The following is a description of a gene set: from publication Luckey CJ, Bhattacharya D, Goldrath AW, Weissman IL, Benoist C, Mathis D (PMID 16492737) Human Gene Set: GOLDRATH_NAIVE_VS_MEMORY_CD8_TCELL_DN species: Homo sapiens The only cells of the hematopoietic system that undergo self-renewal for the lifetime of the organism are long-term hematopoietic stem cells and memory T and B cells. To determine whether there is a shared transcriptional program among these self-renewing populations, we first compared the gene-expression profiles of naïve, effector and memory CD8(+) T cells with those of long-term hematopoietic stem cells, short-term hematopoietic stem cells, and lineage-committed progenitors. Transcripts augmented in memory CD8(+) T cells relative to naïve and effector T cells were selectively enriched in long-term hematopoietic stem cells and were progressively lost in their short-term and lineage-committed counterparts. Furthermore, transcripts selectively decreased in memory CD8(+) T cells were selectively down-regulated in long-term hematopoietic stem cells and progressively increased with differentiation. To confirm that this pattern was a general property of immunologic memory, we turned to independently generated gene expression profiles of memory, naïve, germinal center, and plasma B cells. Once again, memory-enriched and -depleted transcripts were also appropriately augmented and diminished in long-term hematopoietic stem cells, and their expression correlated with progressive loss of self-renewal function. Thus, there appears to be a common signature of both up- and down-regulated transcripts shared between memory T cells, memory B cells, and long-term hematopoietic stem cells. This signature was not consistently enriched in neural or embryonic stem cell populations and, therefore, appears to be restricted to the hematopoeitic system. These observations provide evidence that the shared phenotype of self-renewal in the hematopoietic system is linked at the molecular level. Genes down-regulated in comparison of naive CD8 T cells versus memory CD8 T cells., and this is the list of marker genes: CHCHD7 (coiled-coil-helix-coiled-coil-helix domain containing 7), UNC119B, MYADM (NCBI Gene Id 91663), CAPN2, DENND5A, GZMA, PRKCA, CD160, GZMK, IER3, SMYD1, SOCS2, PLCD1, ABCB1, SAMHD1, PBX3, SNX10, KRTCAP2, CRTAM, TSPAN4, CLDND1, CAPG, PRSS12, MAP3K8, RASA4, ST3GAL4, MYL1, PLP2, ENPP1, SEMA4A, MYO1F, ID2, PLBD1, ASAH1, KLRC1, TMEM141, PPP3CC, CYFIP1, ACOT7, TRAF1, VMP1, HCFC1R1, IL10RB, PIP4P2, NCKAP1, S100A6, BHLHE40, ODC1, PLEKHA5, TKTL1, PGAM1, LGALS3, MS4A1, CYBB, IL18RAP, DSTN, SERPINB9, FGL2, TNFRSF1B, BCL2A1, EEA1, CCND3, IL15, CCL5, GATA3, RECK, ANXA2 (annexin A2), CISH, CTNNA1, SERPINB6, FCGRT, SLC66A3, EI24 (EI24 autophagy associated transmembrane protein), SSX2IP, OSTF1, DBNDD2, ABHD5, GK, EYA4, SLC35E4, PTPN13, ATF6, ANXA1, FHIT, EVI2A, PTPN22, RNASE4, ITM2C, CCR2, ANKH, CTSW, SOAT2, PLAT (plasminogen activator, tissue type), CHPT1, FCGR2B, PALD1, TUSC2, CST7, SKAP2, RAB3D, GPC1, EOMES, BCL2L2, LITAF, S100A10, GZMB, POLR1B, KLHL7, AQP9, PGLYRP1, MED10, HIP1R, PHF13, CYP4V2, PRF1, CASP4, GCAT, MDFIC, GGH, CRYBG1, EMP1, CASP1, PRDM1, PLEKHB2, RNF138, KLRK1, HSD17B11, TXNDC5, IL18R1, IL15RA, MGST3, DENND4C, GLRX, TRAF3IP2, YJU2B, CPNE3, BAG3, ANTXR2, S100A13, PLSCR1, DAPK2, GOLM1, ITGAX, CXCR3 (NCBI Gene Id 2833), TK1 (NCBI Gene Id 7083), ART3, MAPK12, IFNG, GOLIM4, KCTD12, VKORC1, S100A4, IRF8 (NCBI Gene Id 3394), ERRFI1, POU6F1, NRP1, KCNJ8, MAPRE2, TMEM37, CCL4, STARD10, LIMD1, DOCK5 (NCBI Gene Id 80005), STX7, GCLM, AIF1, LPGAT1, IFITM10, RPGR, GABARAPL2, GZMM, CD22, MCOLN2, ITGB1, ARL6, AHNAK, CCR5, FASLG, SEMA4F, ST3GAL6, SOS2, ECI1, XIST, ELL2, GPHN, KLRG1, GSTO1, CIPC, NOTCH4, LDAF1, SLC25A53, CD44, NBEAL2, CYB5R4, LGALS1, DNAJC5, F2R, N4BP1, ACY1, LPIN1